The following is a description of a gene set: studied in species Homo sapiens Human Gene Set: REACTOME_INFECTION_WITH_MYCOBACTERIUM_TUBERCULOSIS Infection with Mycobacterium tuberculosis, and this is the list of marker genes: DUSP16, SFPQ, ATP6V1H, UBA52, PGK1, MAPK3, B2M, RAB5A, KPNA1, CORO1A, RNF213, NOS2, CTSG, GSK3A, UBC, ENO1, TLR2, UBB, KPNB1, MAPK1, MRC1, TRIM27, LTF, VPS33B, HGS, RPS27A, RAB7A